The following is a description of a gene set: By the 14th week of gestation it is nearly always possible to visualized the fluid-filled fetal stomach bubble on prenatal sonography. This term refers to the absence of a normal fetal stomach bubble on fetal ultrasonography performed at around 16 to 20 weeks' gestation. studied in species Homo sapiens Human Gene Set: HP_ABSENCE_OF_STOMACH_BUBBLE_ON_FETAL_SONOGRAPHY Absence of stomach bubble on fetal sonography, and this is the list of marker genes: NUP88, TRIP11, KIF26A, ADGRG6, ZIC3, ZBTB42, FANCB